The following is a description of a gene set: Neighborhood of CD8A CD8a molecule in the MORF expression compendium Human Gene Set: MORF_CD8A Neighborhood of CD8A species: Homo sapiens, and this is the list of marker genes: PLA2R1, PSG1, TANC2, LORICRIN (NCBI Gene Id 4014), KRT2, ZSCAN26, PART1, APOBEC1, AQP7, ITGBL1, GUCY2F, IGKV7-3, JRKL, KDR, COL8A1, KNG1, CAMK4, R3HCC1L, EPHB2, ITIH3, PHLDB1, CXCL5, ADAMTSL3, MLLT10, MAGEA8, P2RY10, RREB1 (ras responsive element binding protein 1), ZBTB40, NRXN1, SLC22A6, BMP10, TSSK2, S100A5, ZNF157, PDE4D, BCL2L11, ZNF141 (NCBI Gene Id 7700), RUNX2, ARL3, COL14A1, ACKR1, SGCD, COL19A1, HTR1E, HNF1A, MC5R, PGM3, POLR1HASP (NCBI Gene Id 80869), ASB4, LECT2, DBT, EXOC4, ABCC8, KRT34, GLRA3, GPR18, CYP2E1, LGI1, FAS, CCL16, NR1I2 (NCBI Gene Id 8856), PHOX2B, CD8A, TIE1, TMEM26, CADM4, GPR19, ERC2-IT1, RAD51D, OCM, FBXL4, IVL, PLPPR4, IFNA10, SLC15A1, IL11RA (NCBI Gene Id 3590), TBX19, SGPL1, NPFF, ABO, ITGA2, GJB5, FOSL1, ABCB10, ELAVL2, MYT1, CDC73, PVR, HSD3B2, RXRG, COX6A2, SUPT3H, VSTM4, EXOC6B, PCDHGB7, GCA, FGF18 (fibroblast growth factor 18), AOC4P (NCBI Gene Id 90586), PDCD1, POU6F1, SPA17 (NCBI Gene Id 90953), F2RL3, NTNG2, MAP2, FZD5, SLC6A2, SLC4A8, CALN1, RORB, STAC, TENM4, B3GNT3, FSHR (NCBI Gene Id 4959), DMD, GPR171, ATXN3, PTPRB (NCBI Gene Id 5787), ABCB1, SIM2, ADAM20, SERPINA4, NR3C2, KLRC4, MAGEA9, ERCC4, HCRTR2